Given this list of marker genes UBE2D3-AS1, DNAAF4, CEP70, MIR22HG, LNPEP, SLC38A11, LXN, NDUFS4, B2M, GPR108, ELP2, GALM, SEPTIN7-DT, DDX39B, ARMH3, NOP16, RNF6, PMEL, VCP, PFDN1, SIDT2 (SID1 transmembrane family member 2), MT-TL1 (mitochondrially encoded tRNA-Leu (UUA/G) 1), CDK5RAP3, FAM118B, MT-TH, PABPC1P10, TPBG, CDC42SE1 (CDC42 small effector 1), DENND4A, RPL7AP64, TIMM17B, MRNIP, ATP5MC1, POLR3D, LINC01572, MCM7, MRPL24, GET1, GTPBP8, HILPDA-AS1, GRK6, TRUB2, HNRNPAB, DLAT, EEF1A1, ZFAND6, SETD1A, SCARNA16, COA7, IMP4, ARMT1, ILF2, IST1, ENSG00000246308, PTPRK, PRDX2P1, MCM4, CARINH (colitis associated IRF1 antisense regulator of intestinal homeostasis), RPS14, TDP1, EFNA4, ANKRD35, SNORD96A, LRRC61, EIF2AK3-DT, UPRT, SNRPA1-DT, RACK1, UGT3A2, UQCRB-AS1, GFM2, CCNI, SLC20A1, ANKRD10, MAPK10, UBE2C, MIR4636, ZSWIM1, NCAPD2, GRHL2-DT, TEX46, HPGD, MYL12A, UACA, IRF2BP2, RNU6-1289P, CTNNA1, ITGAE, NOL8 (nucleolar protein 8), MAD1L1, NFIC, DCAF7, SUCO, ENSG00000232995, LINC01030, SHC1, ARHGAP5-AS1, TARDBP, EEF1AKMT2, ZFAND3-DT, EMC9, SLC44A3, KIF11, ATP9B, PIK3C2B, BTN3A2, GLI1, PDXP, ANKRD11, MLEC, SNORD18A, AIMP1, IKZF3, MRPL51, IFNAR1, TOMM22-DT, RAB3D, SUMF1, E2F2, RPL35AP35, BZW2, SF3A3, BPGM, AP3B1, ABALON, MT-ND6, CENPP, DPAGT1, OSGEPL1-AS1 (NCBI Gene Id 101409258), MAML1, BUD13P1 (BUD13 homolog pseudogene 1), PGGT1B, AP3M1, CNPY4, NDUFB2, SCARNA13, MBTD1, HMGCR, GCNT3, DNAJC13, SNORA21, PSMG3, SNRPF-DT, SDSL, SNORD49B, EIF4A2 (NCBI Gene Id 63124), TXN2, VTRNA1-2, CD164, TRMT112 (tRNA methyltransferase activator subunit 11-2), LINC02427, HLA-DMA, CASP9, PFDN5, MED16, CCDC18, GDF9, TTC41P, MALAT1, PTDSS1, RSPH3, KBTBD4, VPS45, AVL9, MT-ND1, KCTD16, C20orf96, ENSG00000187951, INO80, ISY1, MT-TK, ARHGDIB, OIP5, LRRC49, ERCC6L2-AS1, NDUFA9, ELOCP18, CLTC, ANKRD13A, EIF4G2, MTF2, ACOT8, LINC01023, MIR4258, CLPTM1, RPS19P1, UCP2, TRABD2A, CDKN2D, GINS1, PDK2, HSPB6, SNX8, MOSPD3 (NCBI Gene Id 64598), SNORD84, ZC3H4 (NCBI Gene Id 23211), ABCE1, KANSL3, SNORD18B, DAD1, DBP, RN7SL724P, PHF5A, MTREX, FAAP24, PLS1, ISG20, CCT5, CERNA3, HDAC2-AS2 (NCBI Gene Id 107986638), SLC25A53, ELAC2, YJU2, MIR3677HG, AXDND1, TMEM117, USP25, TPI1P2, RAB5B, RETREG1-AS1, PPIA, WDR5B, STIL, TMEM139, LINC00434, CENPE, KIAA1191, RAB30, ITPRIP, HMGN4, PHTF2, UNC50, CCNB1IP1, C9orf43, NASP, DMTF1-AS1, AGBL5, ARF1P1, SENP8, HINT1, PSIP1, MT-ND4, SHARPIN, SNORD14E, FBXO16, DNAL4, NUDT2, TMEM205, PTPA, SMARCC1, SPRING1, ST3GAL5, RNU6-1191P, FANCM, PIDD1, SSBP1, PUS10, TALDO1, IMMP1L, SRA1, QNG1, PAPOLA-DT, RGMB, PDZD2, POLR2K, MIR6508, ATG12 (autophagy related 12), EXOSC5 (exosome component 5), CDC45, BLOC1S6, CENPA, RPS8, SPAG7, SEPSECS, ZMYM5, MIR1282, CWC25, HEXA-AS1, SLC25A5-AS1, AGPAT1, UFC1, MYL6, CETN3 (centrin 3), RPL37, MRPS33, MT-TL2, PDP2, ZBED3-AS1, HEXIM1, SP2, HNRNPUL1, EMP1 (NCBI Gene Id 2012), SART3, ENSG00000249236, NBR1, ATP5IF1, CEP170, DIAPH1-AS1, ST6GAL1, MMP2, MRPL13, C1orf131, IMMP1LP1 (NCBI Gene Id 731393), TMEM135, FUS, LINC00910, EEF1D, PROSER3, OR51B2 (NCBI Gene Id 79345), SLC50A1, CNNM2, LRRC41, HDLBP, PCDH1, GDI2 (GDP dissociation inhibitor 2), ANG, NECAB2, MT-TW, PARVG, RBM33-DT, NPM1, RNU6-502P, LSG1, MT-TG, HNRNPC, ZFAS1, BCL6, TMEM68, ARID1A, IFTAP, POLR3A, MAZ, LMBR1L, PCNX4, SMC3, FAM222B, RNA5S17, H2BC8, ZRANB3, SNORD59A, RBM14-RBM4, HARS2, CASD1, POLR1G, ATF7-NPFF, MAD2L1-DT, YTHDC2, TDRKH-AS1 (TDRKH antisense RNA 1), RHBDD3, DHX38, USP54, DDX60L, PTBP1, SNORA62, ZWILCH, MED29, SATB2, ARMC1, MICOS10, ILF3-DT, FAM131B-AS2, DUSP19, MRPS22, MORN4, OCIAD1, GPN1, LINC02320 (long intergenic non-protein coding RNA 2320), CDIPT, MIR638, NHLRC3, DGAT2-DT, CASC11, FGF9, IFI16, RPL8 (ribosomal protein L8, NCBI Gene Id 6132), LINC02141, PMFBP1, UBXN1, RHOF, TOMM20, ARL4A (ADP ribosylation factor like GTPase 4A), TSC22D2, DUT, DNAJA3, PEAK1, QTRT2, GTF2F2, ZNF785, RAB11A, RBM48, PSMD1, SRP19, ARIH2 (ariadne RBR E3 ubiquitin protein ligase 2), GPRC5A, ANAPC10, RPL30P11, NUP107, MIEF2, METTL8, EXOC4, MT-TQ, POLG, EEF1A1P23, TMEM161B, ALAS2, ARMH1, TMEM30A-DT, PLAC8, DBI, TERB1, OXNAD1, SLC5A7, DNAJC16, ARAF, COX4I1, CSNK1A1, NDUFS6, CLU, ATG2A (NCBI Gene Id 23130), EMC1, ZNF684, PPP1R21, SIRT4, GTPBP1, STAM, ELP4, AHCTF1, MGST2, TSEN2, APC, WRAP53, PABPC1, CNTD1, KCTD10, CNGB1, SNRPG, CNOT3, CACYBP, MIA2-AS1, SNORD101, SLC4A11, MT-TA, RPL34, CTSH, SNORA50C, RGS17P1, NDC1, VIM-AS1, ROCK1, TOM1L2, CDKN1B, LINC00467, RPL7L1P8, NIFK-AS1, CGB2, NUFIP2, SNORD35A, NDUFAF4, RUFY1, SNORA72, GABPA, TMEM267, RNU7-123P, SLC38A1, SLC9A1, PNO1, HERPUD1, ARAP3, UIMC1, MIR616, PTCD3, ARSK, MAIP1, CASP8AP2, MT-RNR1, RALY, PCDHGA8, IGF2, TRIT1, INTS9, SNORD4B, SNORD83A, CLK1, RPS23, BUB3, ZCCHC8, ILRUN, ERAL1, DBF4B, SDCCAG8, LMAN2, GRPEL2, SNORD83B, VIM, STXBP5-AS1, TTC8, RPL23, SCNM1, CSPP1, MTERF3, PEX1, MRPS27, YME1L1, DDX39B-AS1, R3HDM1, PRR14, TICRR (TOPBP1 interacting checkpoint and replication regulator), ZNF131, VPS13B, STK10, PICK1, NUP85, NOP53, KRR1 (KRR1 small subunit processome component homolog), UROD, SREBF2, LRR1, ZNF644, MPZL2 (myelin protein zero like 2), PWWP2A, RIBC2, LRPPRC, RPS24, EIF5A, MED24, FBXL19-AS1, BRF2, NUP205, VARS2, MROH8, SELENOH, PPP1R12A (NCBI Gene Id 4659), NADK2, TOP2A, DNAJC28, MAST4, CALN1, UBXN4, KAT6B, NPEPPS, METTL1, MRM3, ARID4A, CHCHD7, UBP1, STRIP1, CCDC59, RPL21P19, SLC25A12, PROSER1, MYCBP2, RPL7L1, HYDIN, GIRGL (NCBI Gene Id 100506098), PHB1, SNORA24B (NCBI Gene Id 109617003), NXT2, DUT-AS1, PPP1R21-DT, UNC45A, CCT2, MRPS11, ZSWIM3, TPM1-AS, RAD17, GART, DNM2, FIBP (FGF1 intracellular binding protein), TTC33, CDKN2B, SEC24A, HNRNPA0, ANKFY1, GHDC, TNPO3, IL23A, GRIPAP1, GPRC5C, CFAP96 (cilia and flagella associated protein 96), MRPL46, GORAB-AS1, ZBTB4, CARS2, MAPDA, PHF12, SRP54-AS1, HMMR, COPS2 (COP9 signalosome subunit 2), LRRC66, JAM3 (NCBI Gene Id 84887), ZNHIT3 (NCBI Gene Id 9326), UBFD1, C2CD2L, MIR5087, MRPL19, EPB41L5, CLIC1, TANK, RPL14P1, TPT1, QRSL1, MAP3K14, SNRPA1, TIMM9, ALKBH8, RNU4-2, MT-CO1, DHODH, GRHL2, ORC5, CISD3, ZNF692-DT, CDC23, RPS6, ENSG00000275740, COMMD6, MIA2, TUBD1, KHSRP, RNFT2, ZNFX1, H2AC11, AKAP9, CENPK, WDR89, MEF2C-AS2, PRDX1, ARHGEF37, ALDOA, MT-RNR2, STAM-DT, GARS1, H3C6, RPS27P5, GTF2IP7, TOMM40L, RBFOX2, CCDC9, SDHB, SFT2D3, PRRG2, ATP13A4, H2AC13, H2AZ2-DT, SRSF2, SNORD87, GTF2H1, ATP1B3, SPRY4, COPS5, RBM14, RPS27, RCAN1, NME7, TAOK3, MMUT, TDRD3, CXorf58, TRMT44, CHD9NB, ZFHX3, EIF2S1 (NCBI Gene Id 1965), PANK3, RAB4B, FBXW11, CDC123, MRNIP-DT, ATP5MC2, GNB4, DNAAF4-CCPG1, CDH8, KIF9-AS1, MEGF11, WHAMM, PACSIN2, MT-ND5, TMEM60, ZBTB11, LRP3, GLCE, PBX1, HISLA, ATOX1 (antioxidant 1 copper chaperone), FBXO24, PET100, CCND3, RPL32P3, ABCB8, ENSG00000260830, RNVU1-22, LINC02065, ZFPL1, IMP3, SETDB1, TRIP10, USPL1, SNX24, SMC1B, LY6G5B (NCBI Gene Id 58496), MASTL, ASH1L, RPS3P6, NOL12, CES3, SUPT7L, NR6A1, SEC61B, TMEM167B, LYRM1, PDXP-DT, KIF3A, TCTA, ITSN1, DYNC1LI2, RBM27, TAS2R42 (taste 2 receptor member 42), DNAJC2P1, SELENOK, PPP1R10, SCP2, USP49, CALD1, PTGES2, OGA (O-GlcNAcase), OTUD7A, RPS25, CCDC183, NUDT5, SNORD54, DNAAF3, UBC, LYSMD1, AGBL5-AS1, MAF1, UNC5B-AS1, TMEM106C, RAP2A, SAMD4B, SPSB1, ARL15 (NCBI Gene Id 54622), GGA1, FIS1, SLC28A2-AS1, SLC27A5, CDCA7, RNFT1-DT, NIPBL, DNM3-IT1, ITFG2, CALM3, PTMA, PEF1, GLRX, RBM47, RPLP0, PCLAF, CPEB4, DDX56, NFATC4, PAPOLA, NDUFA8, NRDC, COX6A1, ACTB (actin beta), ADAT1, ARHGAP5, TMEM260, MRPS30-DT, DPPA2P3, ATP5MG, LCMT2, COX7A2L, UTP6, KDM1A, ATP8A1-DT, SIDT1, EGR1, DHX33, MFSD11, SNORA68, ZNHIT1, ACO2, DPH1 (NCBI Gene Id 1801), USP21, SLC39A6, FCF1, DCAF17, SNORD38B, GTF3C1, RPS7P1, PEX26 (peroxisomal biogenesis factor 26), AP5Z1, CLASP1, CCDC115, LINC01592, SNX9, UFD1, RPS5, PSMD3, CENPW (NCBI Gene Id 503503), TBCA, RPL7AP14, ZBTB22, ERI2, PSMF1, SPDL1, GNB2, PTP4A2, SLC35B1, SCAND1, METTL3, MT-TC, SNORD15B, UQCRB, TIGD6, SNORD42B, FKBP3, RPL22, OARD1, FBRS, VPS52, SEM1, DYNLRB1, ARRDC3, CEP192P1, CTSO, MEPCE, PEF1-AS1 (PEF1 and COL16A1 antisense RNA 1), RECQL, ADGRF3, KIF2C, ATP5F1AP2, TEPSIN, WBP1, YIPF1, ARID5B, EVI5L, TAF9, FHIT, LPXN, RAB30-DT, TBC1D19, ZFP91, KLHL7, MRFAP1L2 (NCBI Gene Id 93623), DPP9, TBC1D17, SLC12A9, XPNPEP1, HIGD1AP16, CNBD2, CPSF2, MATN3, TRIM41, RWDD1, RNF207, NOSIP, SEPSECS-AS1, VMAC, BTN3A1, HACE1, NPC2, SNORD95, CCDC124, KIAA0586, RABIF, ZNF219 (NCBI Gene Id 54166), CDKL5, SKIDA1, PPM1L-DT, PAF1, ACAD9, TAF8, PUM3, DSTYK, PRDX2, ZNF609, NPTN, PSMD7, PPRC1, CFAP418, MOCS2-DT (MOCS2 divergent transcript), PHLPP2, MATR3, MYO9B, PIGF, OR13C9 (NCBI Gene Id 81375), DMTF1, SNORD13, ANKRA2, LPCAT3, TK2, MYNN, MRPS21, RNA5SP219, SNHG29, RPL19, BBS2, NUMB, ECH1, POLQ, CFAP68, TAF15, HINFP, WDR59, FBXO9, GTF2H4, TMBIM6, INO80B-WBP1, PLEKHH3, RNF121, ERP29, KIF18A, MRPL36, LRCH4, POLE3, TSN, ENSG00000236403, MGST3, RASGRF2, UQCRC2, TIMM8B, GRAMD2B (NCBI Gene Id 65983), CACTIN, NEMF, MRPL11 (NCBI Gene Id 65003), UBLCP1, UBL7-DT, IFRD1, ABHD12, HBP1, SLCO4C1, SV2C, ZNF689, CTH, XRN1, CORO7, RC3H2, ORC6, TUBA1B-AS1, RNA5SP18, SIPA1L3, SEPTIN7, SYNGAP1, HEXA, GLG1, SEC14L1 (SEC14 like lipid binding 1), MDP1, MAD2L1, BSDC1, EMP3, ARMH4, ADPRHL1, CNOT1, H2AC8, NAV1, EIF3B, ATP8A1, RPL5, KRT15, USP48, PRMT1, LARS1, NUP107-DT, CCDC86, HSPA9, GNAL (G protein subunit alpha L), MOB4 (MOB family member 4, phocein), ZNF561-AS1, MYO19, TOX4, MTMR4, ZNF239, CPLX2 (complexin 2), NUP62, ACADM, SUGCT, KDSR, SOX2-OT, HOXA9, RTN4IP1 (reticulon 4 interacting protein 1), TMEM231, ZSCAN31, RANGAP1, DNAJC19, PCNX4-DT, ATP10B, SKIC3, ANKIB1, ENSG00000255647, RNF145, C1GALT1, CENPM, SNORD12C, INAVA, RPLP1, DCUN1D3, KRT18P31, CDIPTOSP, VPS33A, SMC2 (NCBI Gene Id 10592), COQ4, TESK2, MT-TS2, PEX13, VIL1, NFU1, TTI2 (TELO2 interacting protein 2), MGAT1, SELENOI, LINC02817, NLK, MIR3912, SLX4IP, MCTP1, CDCA5, HOXB3, ACSL5, RNU6-1, USF3, AHCYL2, TYW1B, POLR2A, SP2-AS1, NOP2, BCKDHA, ALDH18A1 (NCBI Gene Id 9193, aldehyde dehydrogenase 18 family member A1), CDK16, TRIM33, NDUFA2, CENPN, ZNF408, PDPR2P, ATP6V1D, MYG1, DBT, MMADHC, CDON, SNORD38A, BORA, MNS1, YIPF5, ARHGAP1, MFAP1, C19orf48P, AP2A1, LRP10, MED19, AURKA, GTPBP3, MPLKIP, RNU5D-1, SRP54, MPV17L2, LINC01545, SERINC4, BTBD7P1, SNORA33, RPL4P4, SIK3, ETFBKMT, COPE, PCBP1-AS1, MTIF3, CYB5B, DENND1B, PBK, LENG1, RAD21, COQ8A, DGAT2, BTF3, SLC12A8, BPNT1, XNDC1N, TCERG1 (NCBI Gene Id 10915), VIPR2, RNU6-2, RSRC2, NUF2, RPS15A (ribosomal protein S15a), RHOA, SNORA31B (NCBI Gene Id 109616966), ABT1, SNORD43, PHPT1, MT-ATP6, RPS23P8, LYSMD3, PLBD1, SLC2A8, ENSA, TAF12-DT, WDR5B-DT, CHD2, AK6, RPL3, NAE1, LIAT1, TRAF3IP2, FAM228B, ANXA2R-OT1, PRR13, BLZF1, CROCCP2, BBX, RAB4B-EGLN2, TNPO1, LSM8, SLC9C2, TXNDC17, CRIPT, RAD54B (NCBI Gene Id 730560), DLG2, ZFAND3, RPS12, PPP6R3, MICOS10-NBL1, FRYL, FBXO48, RNU6-728P, KRBA2, DHX29, RPL23A, SNX15, HYCC2, PSRC1, CDC25C, SNORA9, TTC23, GLOD4, MINDY2, HMGB3P22, GHR, MPP1, CCNB2, PSMA6, CNOT6, RPL30, CKS1B (NCBI Gene Id 88475), MRPS30, ARRDC4, NUDT15, COX7C, PSMD7-DT, MT-TY, WDR75, TJP3, CRYZL1, RNU6-9, CHP1, MST1P2, BCL2L1, ZBED5, GLO1, ERCC1, UTP15, MPP7-DT, NACA, KCTD9, MIR4727, MTR, CHST4 (NCBI Gene Id 10164), MARCHF9, KCNIP2-AS1, LAMC1, LINC01089, NCLN, KIF3C, WDR31 (NCBI Gene Id 114987), HPR, IFT52, ANKMY2, RPLP2, CIAPIN1, HNMT, ATP6AP1L, HYAL2, EWSAT1, MT-ND3, MFSD14CP, H2AZ2, THAP10, AKTIP, FCSK, TMEM167B-DT, ATPSCKMT, OASL, SYF2, DNAJB9, NSA2, ENSG00000275765, HMBS, ALKBH3-AS1, MOV10, PPBPP2, TIAM1, FBXO33, MT-TT, DCTN4, CUL2, SUCLG1, NAA38, LSR, CDKL3, MED7, CLYBL-AS1, SPC25, CCNH, GABPB2, FBXL19, PPM1L, RPL7A, UBE2D3, CAMKMT, POC1B-GALNT4, TMX2, BAZ1B, XAB2, AFG2B, ETS2-AS1, CCDC191, ENO3, PPP2CA, SCAF11, SCAMP3, HTD2, NDUFB3, CKLF, PRMT2, AP3S1, PAN2, ATP2C1 (ATPase secretory pathway Ca2+ transporting 1), SLC30A5, MRPL48, ZNF783, USP36, MYL5, LDHB, RPL34-DT, EXTL2, SNORD36A, KLHL20, SNORD33, KATNIP, CRAT, SNAPC5, LVRN, UQCC6, MKKS, IRF2BP1, CREBBP, SDHD, JMJD1C, MNT, TAF6, RPS29, TPRA1, MRPS18B, SCAMP1, BORCS8-MEF2B, TMEM106B, ZNF687, DPRXP1, TARBP2, EMSY, HCCAT5, RPA3, AP1G1, KIF2B, PPP2R5B, TMEM30A, CDCA2, H2BC5, ZNF143, PLSCR1, TACC1, PNN, ADO, COPS4, DCP2, C5orf52, CD96, RNU5B-1, ATP5PO, TDRKH, ERCC6L2, UBE2T, WDR55, ARF5 (NCBI Gene Id 381), ARL14EP, DNAAF10, UBE3B, CEP89, ARPC2, LRRC28, ZBTB5, HNF4A, ITFG2-AS1 (NCBI Gene Id 647957), CRTC2, GAR1, HOXA10-AS, SLC26A7, DCAF11, MIR7111, ANKRD13C (NCBI Gene Id 81573), ZNF165, PDS5B, OSGEPL1, RNFT1, NUDT9, RNVU1-21, TMED1, CTDSPL2, TPD52, PPP1R13L, TOMM7, MT-TE, STMN1, PKD1L3, IFT74-AS1, GPC5-AS1, SMARCA2, PLOD3, GTF3C5, PSMB3, PIK3R3, TYW5, CENPQ, CHCHD2, ITPRID2, MKLN1, UBIAD1, ILF3, ATP5F1B (NCBI Gene Id 506), NUDCD2, DIP2C, SNHG10, BOK, SQSTM1, NFE2L1, EIF2AK3, C1orf174, DPH3, CSTF2T, MCTS1 (NCBI Gene Id 28985), ZNF839, CCDC174, DRC3, SARNP, RCC1, CEP120, PNPO, RNU11, SNX30-DT (SNX30 divergent transcript), MT-ND4L, C2orf76, PRKCI, MT-TR, DIAPH1 (NCBI Gene Id 1729), EFNA4-EFNA3, SNORD42A, TRAPPC8 (NCBI Gene Id 373175), C5orf34, UTP18, RPS13, UFSP2, PAIP2, MRGPRX6P, RBM42, RFXANK, PNISR, RPS21-DT, CIC, HNRNPD, SMAP2, ZNF778, ZNF398, SNAPC3, RPF2, SAP30BP-AS1, HILPDA, TENT4A, EFCAB7, CCNJ, OAZ2, METTL5, EIF3E, MIR626, EWSR1 (EWS RNA binding protein 1), ATM, ZNF33A, ENSG00000282936, NPRL2 (NPR2 like, GATOR1 complex subunit), GOLT1B, CTDSPL2-DT, SNORA70, MIR4638, ATF7, TOMM40, KATNB1, METTL15, IQCG, KSR2, ALB, CNOT10, LUC7L, TMEM109, ZCWPW1, SRRT, PIF1, CRISPLD2, RPS27AP16, RNU6-1301P, TMEM14B, SNORD36B (NCBI Gene Id 26814), CCNB1, RPS27A, MGRN1, SMYD5, NKAPD1, ZNF391, FAM53C, YJEFN3, HOXB-AS3, LARP4, PRKDC, VASP, NUMA1, TIMM8A, PQBP1, CYLD, PNPLA8, SLC25A5, SETD2, ALG2, H2BC13, AARSD1 (alanyl-tRNA synthetase domain containing 1), MROH1, ACTR3C, CMC2, MT-TF, CHASERR, PTPN13, FXYD3, ZNF786, HMGB1, RFWD3, DST (NCBI Gene Id 80105), LRRC57, HP, H2BC11, LINC01932, MRTFA, ANKRD54, RN7SKP134, PLAAT3, CACNB2, SNORD111, HDGFL2, TARS2, NDUFB1, TEDC1, ORC1, CENPU (NCBI Gene Id 79682), DDI2 (DNA damage inducible 1 homolog 2), HAVCR2, MRTO4, TOMM22, NDUFA11, TXNL4B, FABP5P9, MZT1, MGAT4B, CMSS1, MSL2, HSP90B1, SPRY1, MSH2, RPUSD4, SERPINB8, CCDC77, YARS1, NDUFAF1, FSTL4 (NCBI Gene Id 23105), ZNF691-DT, SLC33A1, TEX15, RNU5E-4P, AP4M1, NFYA, BORCS8, RHOQ, CCDC121, MSL1, MTCO3P12 (MT-CO3 pseudogene 12), XPO1, SNORD55, SPMIP1 (NCBI Gene Id 100508700), USP1, RPS3, NDUFAF8 (NCBI Gene Id 284184), RNY1, ZNF695, SLC3A2, POC1B, NDUFAF4P1, SNORD14A, AFAP1, G3BP1, OGN, RPS18, GOLPH3L, ACOX2, ATF5, PPWD1, HNRNPA2B1, PIGQP1, CANT1P1, TNFAIP8, DOHH, RPL30-AS1, HNRNPA1, ITGB3BP, IL4I1, AKT1S1, PTGES2-AS1, FASTKD5, PTCH1, APLF, HLA-DPA1, TNRC6B, SEMA3C, RPL13P12, RNF41, UBL7, EIF1, IK (IK cytokine), RMND1, EXD1, ARHGEF3, NPM1P21, SAMTOR, MYC, NAXE, ENC1, PXN-AS1, HOMER1, AREL1, PTPN4, VPS35, ZBED3, TLE3, TTC32-DT, P4HB, PLCZ1, POLR1A, LIPE-AS1, DNMT1, UQCRH, PTPN21, RPL13A, EFHC1, SNORD34, STK31, KIAA0753, POC1A, MT-CO3, ZNF561, MT-TI, STARD4, NEPRO, MTBP (MDM2 binding protein), R3HDML-AS1, FEM1A, CCDC159, HARS1, TMEM14A, SNHG15, ETV5, IER5, ZNF460, C19orf53, TFG (trafficking from ER to golgi regulator), SNORD35B, EMSY-DT, RPS6KB1, SELENOP, DDAH2, SATB1, METTL25, MTMR12, H2AC4, CA11, RSL24D1, MRPL37, ZNF774, RIN1, MCEE, SNX30, BTF3-DT, RPL27A, ASB8, AP3S2, HIGD2A, TK1, ACBD6, ZCCHC7, CNOT8, SNRPD1, MT-TN, PLEK2, N6AMT1, PIP4P1, ZNF77, LCA5L, TSACC, ZNF692, RPL4, DDX49, LAPTM4A-DT, STX5-DT, UBOX5, PRPF38A, MICAL3, RTTN, SUN2, FBXO38, CLN3, SYNCRIP, MTHFD2L, HMGCS1, TMCO6, MIR5188, GCDH (NCBI Gene Id 2639), PPP5D1P, CYB5D1, ADK, VPS41, CLDN4, MTND5P11, FLCN, AFMID, VPS13B-DT, DGKA, RPRD1B, PANK1-AS1, SIAH1, MYO9A, HSPA8, ZNF691, PARP14, NDUFA4, BBC3, ANAPC5, PREPL, CCT3, CHTOP, CNPY3, ZBED5-AS1, BRCA1, TMEM161B-DT (TMEM161B divergent transcript), RGS9, BCAS3, UBB, HMBOX1, ING1, HOXC-AS2, LINC02003, OPA1, GOLM2, GNA12, MSANTD4, NAPA-AS1, GET3, ENSG00000261260, AKAP3, CANX, C21orf91, ACOX3, MON1B, WDR83, TMEM94, ACTL6A, TMEM259, ADAMTSL5, ANAPC16, HNRNPH1, PAWR, TUBB4BP4, LRRC1, COX18, HCG14, UPF2, AFF4, HDAC2, ATAD2, ORMDL2, IFT74, LMAN2L, THAP5, CCDC91, ZW10, INO80B, DMD, MT-ATP8, PAXIP1-AS2, STARD13, TRAPPC4, IFT56 (NCBI Gene Id 79989), DLGAP1-AS2, PANK1, PPP2R2D, SINHCAF, CUX1, MICOS10-DT, ASCC1, BLCAP, FDPS, MIR6797, PIH1D2, MIR6747, OTUB2, RNU7-27P, PPP2R1A, RNF43, RGS5, ST7L, RIOK2 (NCBI Gene Id 55781), RPL35A, ZNF687-AS1, TMEM160, LBHD1, POR, ZNF440, HDAC8, SBF2, ZYX, MOCS2, FXYD5, MIR4276, POC5 (NCBI Gene Id 134359), B3GALNT2, EEF1AKMT3, TBCK, GLRX5, RPF1, MCM3, MAN2A1, PRPF3, ABHD2, BMAL2, VPS18, OCIAD1-AS1, ZNF628-DT, SNHG20, RPL28, C19orf25, KPTN, CSTF1, MUC19, ZFP91-CNTF, WDR83OS, CCNG1, HPS5, RPL10, HELLS, MIR3661, TRIP4, DMXL2, THRAP3, RPS4Y1, RIGI, STX5, DYRK2, CLDN12, GON4L, TANK-AS1, LINC02960, MT-TV, FBXL17, RNF167, CYB561D2, LOHAN2, SNORD14C, ZZZ3, TNFSF9, NRG3, ACHE, TAT, ARHGAP11B-DT, RN7SL774P, S100PBP, BMAL1, WEE2-AS1, UBE2B, ENSG00000239137, RNF5, SLC25A51, SFPQ, CNKSR1, PSMA3-AS1, HASPIN, SEPTIN2, SERPINB1, MT-TS1, HAX1, ZNF668, GNAI3, PIPOX, MAST4-AS1, MACC1, RARS1, AMACR, SEC1P, TTC32, FABP5P3, PTEN, TAF12 (TATA-box binding protein associated factor 12), ATF6, CKLF-CMTM1 (CKLF-CMTM1 readthrough), PLEKHG1, PIGW, LRP6, MFN1, SNORD118, ISY1-RAB43, SLC25A11, SNORD36C, CLNS1A, NDUFS3 (NADH:ubiquinone oxidoreductase core subunit S3), TNC, RNU6ATAC, ATL2, QRICH1, RPN2, MAP4K3, IFT27, HAUS8, RGMB-AS1, RNF139-DT, NUSAP1, CYP4F26P, EIF3F, CLN6, BNIP1, VTRNA1-1, EFCAB11, EIF3D, ZNF143-AS1, IPP, PSMG1, SLC4A1AP, RPS4X, PKN2-AS1, RNPS1, TMEM53, GAR1-DT, RPP14, VPS50, EEF1G, SNORD2, OTUD7B, CAND1, YEATS4, HYPK, SRSF7, SMAD3, ATG101, KNL1, SNORD104, MIR3913-1, PSMD6, NGDN, WASF2, SBDSP1, ZC3HC1, TMEM218, HMG20A, SNORD14D, RPL18, CD63, SNHG25, PRDX5, LINC01843, C11orf54, CYSTM1 (NCBI Gene Id 84418), SEPTIN8, here is a description of the gene set: Genes containing one or more binding sites for (ZFHX3) in their promoter regions (TSS -1000,+100 bp) as identified by GTRD version 20.06 ChIP-seq harmonization. from publication Yevshin I, Sharipov R, Kolmykov S, Kondrakhin Y, Kolpakov F (PMID 30445619) studied in species Homo sapiens Human Gene Set: ZFHX3_TARGET_GENES